The following is a description of a gene set: Any process that stops, prevents, or reduces the frequency, rate or extent of the chemical reactions and pathways resulting in the breakdown of nucleotides. species: Mus musculus Mouse Gene Set: GOBP_NEGATIVE_REGULATION_OF_NUCLEOTIDE_CATABOLIC_PROCESS, and this is the list of marker genes: Sirt6, Ncor1, Sik2, Myog, Fbp1, Actn3, Pfkfb1, Ddit4, Git1, Ppargc1a, Stat3, Slc4a1, Gpi1, Nupr1, Trim63, Cbfa2t3, Tigar, Mtch2, Ppara, Ier3, Hdac4, Ppp2ca, Flcn, Prkaca